The following is a description of a gene set: The chemical reactions and pathways involving an mRNA encoding a histone. studied in species Mus musculus Mouse Gene Set: GOBP_HISTONE_MRNA_METABOLIC_PROCESS, and this is the list of marker genes: Ncbp1, Lsm1, Upf1, Xrn1, Atm, Tut7, Cpsf3, Tut1, Lsm10, Tut4, Zfp473, Lsm11, Ncbp2, Cpsf2, Dcp2, Tent2, Mblac1, Mtpap, Ssb, Tent4b, Exosc10, Slbp, Eri1, Exosc4